Given this list of marker genes H4c11, H3c1, H3c10, Kdm4d, H3c8, Kdm1b, H4c3, H3c6, Phf2, H4c12, H3c2, H4c2, Arid5b, Kdm6a, Phf8, Kdm1a, Kdm4c, Kdm7a (lysine (K)-specific demethylase 7A), H4c18, H3c7, H3c3, H4c1, H4c8, H4c6, H3c15, Kdm6b, H4c17, H3c13, H4c14 (H4 clustered histone 14), Kdm2b, H3c4, H4c9, H4c4, H3c11, here is a description of the gene set: Reactome Pathway: HDMs demethylate histones electronically inferred by orthology from the curated human pathway part of: Chromatin modifying enzymes studied in species Mus musculus This event has been computationally inferred from an event that has been demonstrated in another species.<p>The inference is based on the homology mapping from PANTHER. Briefly, reactions for which all involved PhysicalEntities (in input, output and catalyst) have a mapped orthologue/paralogue (for complexes at least 75% of components must have a mapping) are inferred to the other species.